Given this list of marker genes RPS17, ATP5ME, RPL37, COX7C, CHRNB1, PKM, PDLIM5, MYF6, STK17B, ZNF623, RPS21, TK1, CRYBA4, NR4A2, RPL37A, SEC61G, SPTBN1, RPL38, RPS23 (NCBI Gene Id 6228), TUBB2A, MYL6, NDUFC1, HSP90AB1, STAT6, ZNF330 (NCBI Gene Id 94900), NOL7, NCBP2, HMGCS2, RPL34, ERCC2, GPAA1, PPBP, HTR4, DYNLL1 (NCBI Gene Id 8655), GUK1, COL11A1, RNU1-11P, COX17, PLXNA3, LINC03124, ANXA2, NDUFA1, RPL30, OAS2, PGK1, SNRPE, RPL36A, HEXIM1, TXN, RPS27, IL6, CHRNB4, TSC22D1, COX7A2, NREP, RANBP1, UQCRB, MVP, RPL31, CST6, CXCR3, ANXA2P3, here is a description of the gene set: To gain insight into the transformation of epidermal cells into squamous carcinoma cells (SCC), we compared the response to ultraviolet B radiation (UVB) of normal human epidermal keratinocytes (NHEK) versus their transformed counterpart, SCC, using biological and molecular profiling. DNA microarray analyses (Affymetrix), approximately genes) indicated that the major group of upregulated genes in keratinocytes fall into three categories: (i). antiapoptotic and cell survival factors, including chemokines of the CXC/CC subfamilies (e.g. IL-8, GRO-1, -2, -3, SCYA20), growth factors (e.g. HB-EGF, CTGF, INSL-4), and proinflammatory mediators (e.g. COX-2, S100A9), (ii). DNA repair-related genes (e.g. GADD45, ERCC, BTG-1, Histones), and (iii). ECM proteases (MMP-1, -10). The major downregulated genes are DeltaNp63 and PUMILIO, two potential markers for the maintenance of keratinocyte stem cells. NHEK were found to be more resistant than SCC to UVB-induced apoptosis and this resistance was mainly because of the protection from cell death by secreted survival factors, since it can be transferred from NHEK to SCC cultures by the conditioned medium. Whereas the response of keratinocytes to UVB involved regulation of key checkpoint genes (p53, MDM2, p21(Cip1), DeltaNp63), as well as antiapoptotic and DNA repair-related genes - no or little regulation of these genes was observed in SCC. The effect of UVB on NHEK and SCC resulted in upregulation of 251 and genes, respectively, and downregulation of genes in NHEK and genes in SCC. To further analyse these changes, we used a novel unsupervised coupled two-way clustering method that allowed the identification of groups of genes that clearly partitioned keratinocytes from SCC, including a group of genes whose constitutive expression levels were similar before UVB. This allowed the identification of discriminating genes not otherwise revealed by simple static comparison in the absence of UVB irradiation. The implication of the changes in gene profile in keratinocytes for epithelial cancer is discussed. from publication Dazard JE, Gal H, Amariglio N, Rechavi G, Domany E, Givol D (PMID 12771951) studied in species Homo sapiens Human Gene Set: DAZARD_UV_RESPONSE_CLUSTER_G1 Cluster G1: genes most highly up-regulated in NHEK cells (normal keratinocyte) between 6 h and 12 h after UV-B irradiation.